Given this list of marker genes BCL3, HERC5, ANXA3, DDX60, C1QB, RARA, IFIH1, CXCL10, OAS1, PML, IL1B, IFIT1, SERPING1, CARD9, DHX58, IRF7, RIGI, OAS3, RSAD2, here is a description of the gene set: from publication Nakaya HI, Clutterbuck E, Kazmin D, Wang L, Cortese M, Bosinger SE, Patel NB, Zak DE, Aderem A, Dong T, Del Giudice G, Rappuoli R, Cerundolo V, Pollard AJ, Pulendran B, Siegrist CA (PMID 26755593) species: Homo sapiens The dynamics and molecular mechanisms underlying vaccine immunity in early childhood remain poorly understood. Here we applied systems approaches to investigate the innate and adaptive responses to trivalent inactivated influenza vaccine (TIV) and MF59-adjuvanted TIV (ATIV) in 90 14- to 24-mo-old healthy children. MF59 enhanced the magnitude and kinetics of serum antibody titers following vaccination, and induced a greater frequency of vaccine specific, multicytokine-producing CD4(+) T cells. Compared with transcriptional responses to TIV vaccination previously reported in adults, responses to TIV in infants were markedly attenuated, limited to genes regulating antiviral and antigen presentation pathways, and observed only in a subset of vaccinees. In contrast, transcriptional responses to ATIV boost were more homogenous and robust. Interestingly, a day 1 gene signature characteristic of the innate response (antiviral IFN genes, dendritic cell, and monocyte responses) correlated with hemagglutination at day 28. These findings demonstrate that MF59 enhances the magnitude, kinetics, and consistency of the innate and adaptive response to vaccination with the seasonal influenza vaccine during early childhood, and identify potential molecular correlates of antibody responses. Human Gene Set: NAKAYA_PBMC_FLUAD_IMUVAC_MALE_AGE_14_27YO_CORRELATED_WITH_HAI_RESPONSE_MF59_ADJUVANTED_AND_NON_1DY_GENES_IN_BTM_M75_POSITIVE Genes positively correlated with HAI response in peripheral blood mononuclear cell in children (14-27m) (MF59-adjuvanted and non-adjuvanted) after exposure to Fluad/Imuvac, time point 1D. Comment: Genes in BTM M75